The following is a description of a gene set: studied in species Mus musculus Mouse Gene Set: GOBP_XENOBIOTIC_TRANSPORT The directed movement of a xenobiotic into, out of or within a cell, or between cells, by means of some agent such as a transporter or pore. A xenobiotic is a compound foreign to the organism exposed to it. It may be synthesized by another organism (like ampicilin) or it can be a synthetic chemical., and this is the list of marker genes: Abcb1a, Slc22a6, Abcc2, Oscp1, Abca3, Atraid (NCBI Gene Id 71668), Gja1, Slc19a1, Slc22a1, Abcb4, Abcg3, Abca8a, Ralbp1, Slco2b1, Slc18a2, Slc47a1, Abcb5, Slco1a1, Abcc6, Slc2a1, Slc15a2, Slc43a3, Slc17a3, Slc22a2, Slc22a8 (NCBI Gene Id 19879), Slco1b2, Slc7a5, Slc29a4, Slc18a1, Tmem30a, Cldn1, Abcc1, Abcb11, Slc22a4, Abcg2, Slc31a1, Abcc5, Slc47a2, Atp8b1, Abcc4, Abcc3, Nr1i2, Abcc10, Abca8b, Slc22a18, Slc22a3, Slc37a3, Abcb1b